Given this list of marker genes DBNL, DSP (desmoplakin), H1-5, ROCK1, PAK2, TJP1, GAS2, DSG1, FNTA, BIRC2, STK24, HMGB2, CASP6, DNM1L, KPNA1, BCAP31, HMGB1, PTK2, SATB1, DFFA, DSG3, SPTAN1, CTNNB1, H1-1, GSN, CASP8, PKP1, OCLN, TJP2, PRKCQ, ACIN1, H1-0, BMX, H1-2, H1-4, CASP3, LMNB1, PRKCD (NCBI Gene Id 5580), MAPT, APC, LMNA, CASP7, PLEC, DFFB, CLSPN, KPNB1, DSG2, CDH1, VIM, STK26, ADD1, H1-3, here is a description of the gene set: studied in species Homo sapiens Apoptotic execution phase Human Gene Set: REACTOME_APOPTOTIC_EXECUTION_PHASE